Given this list of marker genes HDAC2, NGF, HDAC3, PRDM4, HDAC1, NGFR, here is a description of the gene set: species: Homo sapiens Human Gene Set: REACTOME_P75NTR_NEGATIVELY_REGULATES_CELL_CYCLE_VIA_SC1 p75NTR negatively regulates cell cycle via SC1